Given this list of marker genes Timp3, Nr1d2, Pdgfra, Hsd17b11, Ctla2a, Mt1, Pmp22, Lxn, Tmem176a, Ngef, Prrx2, Prl2c2, Il11ra1, Dhrs7 (NCBI Gene Id 70651), Ddit3, Cdo1, Tmem176b, Dcn, Aldh1a1, Aqp1, Gbe1, Gadd45a, here is a description of the gene set: Mouse Gene Set: BERENJENO_TRANSFORMED_BY_RHOA_FOREVER_UP species: Mus musculus Genes up-regulated in NIH3T3 cells (fibroblasts) transfrormed by expression of constitutively active (Q63L) form of RHOA off plasmid vector; their expression did NOT reverted completely after treatment with Y27632, an inhibitor of ROCK proteins. We have used microarray technology to identify the transcriptional targets of Rho subfamily guanosine 5'-triphosphate (GTP)ases in NIH3T3 cells. This analysis indicated that murine fibroblasts transformed by these proteins show similar transcriptomal profiles. Functional annotation of the regulated genes indicate that Rho subfamily GTPases target a wide spectrum of functions, although loci encoding proteins linked to proliferation and DNA synthesis/transcription are upregulated preferentially. Rho proteins promote four main networks of interacting proteins nucleated around E2F, c-Jun, c-Myc and p53. Of those, E2F, c-Jun and c-Myc are essential for the maintenance of cell transformation. Inhibition of Rock, one of the main Rho GTPase targets, leads to small changes in the transcriptome of Rho-transformed cells. Rock inhibition decreases c-myc gene expression without affecting the E2F and c-Jun pathways. Loss-of-function studies demonstrate that c-Myc is important for the blockage of cell-contact inhibition rather than for promoting the proliferation of Rho-transformed cells. However, c-Myc overexpression does not bypass the inhibition of cell transformation induced by Rock blockage, indicating that c-Myc is essential, but not sufficient, for Rock-dependent transformation. These results reveal the complexity of the genetic program orchestrated by the Rho subfamily and pinpoint protein networks that mediate different aspects of the malignant phenotype of Rho-transformed cells. from publication Berenjeno IM, Núñez F, Bustelo XR (PMID 17213802)